The following is a description of a gene set: Genes negatively differentially expressed in cell type: Monocyte upon treatment with cytokine: IFN-β in mouse lymph nodes in vivo. from publication Cui A, Huang T, Li S, Ma A, Pérez JL, Sander C, Keskin DB, Wu CJ, Fraenkel E, Hacohen N (PMID 38057668) Mouse Gene Set: CUI_MONOCYTE_IFNB_RESPONSE_DN studied in species Mus musculus Cytokines mediate cell-cell communication in the immune system and represent important therapeutic targets. A myriad of studies have highlighted their central role in immune function, yet we lack a global view of the cellular responses of each immune cell type to each cytokine. To address this gap, the authors created the Immune Dictionary, a compendium of single-cell transcriptomic profiles of more than 17 immune cell types in response to each of 86 cytokines (>1,400 cytokine-cell type combinations) in mouse lymph nodes in vivo. A cytokine-centric view of the dictionary revealed that most cytokines induce highly cell-type-specific responses. For example, the inflammatory cytokine interleukin-1β induces distinct gene programmes in almost every cell type. A cell-type-centric view of the dictionary identified more than 66 cytokine-driven cellular polarization states across immune cell types, including previously uncharacterized states such as an interleukin-18-induced polyfunctional natural killer cell state., and this is the list of marker genes: Susd3, Gltp, Fth1 (NCBI Gene Id 14319), Madd, Fau, Clec4a2, Plbd1, Eef2, Cd74, Rras, Dusp1, Gpx1, Lrp1, Metrnl, Arl5c, H2ac24, Arhgap9, Eif1, Cox7a2l, Slc38a2, Gpsm3, Emp3, Zdhhc20, Csf1r, Limd2, Smim29, Tgfbi, Ptpn12, Spag9, Il1b, Trps1, Arglu1, Cdc42ep3, Cd300a, Coro1a, Otulinl, Fos, Cx3cr1, Adgre4, Cyp4f16, Tmem176a, Irak4, Mtdh, Klf4 (NCBI Gene Id 269540), Fcgr2b, Lpl, Eef1b2, Naca, Ypel3, Tomm5, Eef1a1, Gngt2, Ifngr1, Fosb, Klf2, Abi3, Tmem176b, Hpgd, Ldlrad3, Rap1a, Btg1